The following is a description of a gene set: Human Gene Set: MODULE_125 Genes in the cancer module 125. studied in species Homo sapiens, and this is the list of marker genes: PRIM2, RBBP4 (RB binding protein 4, chromatin remodeling factor), CDK2, NAP1L1, TOPBP1, PRIM1, CDC45, SSBP1, LIG1, CDC7, RFC2, BRCA2, PCNA (NCBI Gene Id 5111), POLA1, POLD2, ORC1, CHAF1B, TOP2A, GMNN, POLD1, FEN1, TERT, CENPF, RNASEH2A, RRM1, CENPE, S100A11, RFC5, LIG4, HMGB1, DDX11, RRM2, POLE, BLM, RPA1, RPA3, RFC3, POLE2, RPA2, MCM3, CHAF1A, MCM6, RFC4, TENT4A